The following is a description of a gene set: Mouse Gene Set: WP_ALZHEIMERS_DISEASE species: Mus musculus Alzheimer's disease, and this is the list of marker genes: Gsk3b, Hsd17b10, Plcb1, Bid, Cdk5, Tnfrsf1a, Cacna1d, Atp2a1, Psen1, Gnaq, Apaf1, App, Grin2a, Adam17, Plcb3, Chp1, Cdk5r1, Grin1, Nae1, Ryr3, Mapk1, Apbb1 (amyloid beta precursor protein binding family B member 1), Calml3, Tnf, Psenen, Ppp3cb, Casp3, Itpr3, Ncstn, Plcb2, Mapk3, Grin2d, Atf6, Apoe, Casp12, Cacna1f, Grin2b, Ide, Cacna1s, Snca, Ppp3r1, Capn1, Bad, Atp2a2, Psen2, Trp53 (transformation related protein 53), Eif2ak3, Lrp1, Mapt, Fas, Lpl, Grin2c, Adam10, Mme, Itpr2, Ppp3cc, Calm4, Casp9, Nos1, Cacna1c, Il1b, Bace1, Chp2, Ppp3ca, Itpr1, Casp7, Capn2 (calpain 2, NCBI Gene Id 98318), Ern1 (endoplasmic reticulum to nucleus signalling 1), Ppp3r2, Plcb4, Aph1a, Casp8, Calm2, Atp2a3